Given this list of marker genes CDCA8, RAD54L, TTK, E2F8, POLE, MT2A, REEP5, PMF1, BIRC5, ANXA2, LMNB1, TGM4 (transglutaminase 4), USP4, WDHD1, SHCBP1, MTCH1, ARHGAP11A, RRM1, ANP32E (NCBI Gene Id 81611), PPP2R1B, HELLS, BRCA1, ATAD5, RAD51AP1, SYCE2, BRIP1, CRIP1, CKAP2, TXNRD1, RAD51, MCM5, BUB1B, NEIL3, CDKN3, PYCARD (PYD and CARD domain containing), DNA2, DEPDC1, CTSD, PRIM1, FBXO5, AURKB, KIF23 (kinesin family member 23), SMC2, MCM4, ECT2, KNL1, NHLH1, CKS1B, KIF15, RBM44, CDK1, ORC6, KIF11, CHEK1, IFITM1, DLGAP5, TOP2A, HDLBP, CORO2A, BRCA2, LRR1, INCENP, ARHGAP19, TACC3, SGO2, MT1A, CCNA2, LRRC58, HNRNPA3, BUB1 (BUB1 mitotic checkpoint serine/threonine kinase), ANAPC5, CDC6, NCALD, TADA2A, CSPP1, GZMA, TK1, VCP, CENPS, GNAI2, APOBEC2, SKA1, NCAPH, HIP1, ITGAX, CPOX, SPATA31F3, ANXA4, WDR76, ROM1, MCM7, LIG1, MYO5A, PTGR1, CLSPN, CENPP, ITGAM, TSPAN32, KIF14, ESCO2, MRPS11, TUBE1, NDC80, NCAPD2, PMM1, PCDHB6, STMN1, NCAPG, ZBTB32, KIF4A, TIPIN, NUF2, CBX5, MCM3, FIGNL1 (NCBI Gene Id 63979), RRM2, ASPM, TPX2, PRR11, CENPE, IFNA6, TCF19, RACGAP1, MYBL1, PPP6C, ARF6, EIF5A2, FKBP5, CDC25C, DUT, CPT1A, PLEKHO1, PRC1, AURKA, CCNE1, CDC45 (NCBI Gene Id 8319), CDCA3, VIM (vimentin), H2BP2, PRDX4, SPC24, SPC25, EME1, CENPF, CHAF1B, FHL2, BSCL2, UHRF1, PALM, MKI67, MAD2L1, HMGB3, CCNB2, GGT1 (NCBI Gene Id 91347), SPAG5, CEP55, CENPN, TOPBP1, PBK, KDM4A, RBM45, H4C6, HMMR, NDE1, SGO1, HMGB2, RNASEH2B, GINS1 (GINS complex subunit 1), CALU, PLK1, MIS18BP1, RINL, E2F6, HNRNPUL1, PRKAG1, SLC44A2 (NCBI Gene Id 57368), RFC3, MYADM, NUPR1, TFDP1, PLAC8, H1-5, ASF1B, FKBP2, CENPH, EIF3C (eukaryotic translation initiation factor 3 subunit C), LSP1, here is a description of the gene set: Human Gene Set: GSE13547_CTRL_VS_ANTI_IGM_STIM_BCELL_12H_UP from publication Arenzana TL, Smith-Raska MR, Reizis B (PMID 19329779) Genes up-regulated in B lymphocytes: control versus stimulated by anti-IgM for 12h. The development, homeostasis and function of B lymphocytes involve multiple rounds of B cell receptor (BCR)-controlled proliferation and prolonged maintenance. We analyzed the role of transcription factor Zfx, a recently identified regulator of stem cell maintenance, in B cell development and homeostasis. Conditional Zfx deletion in the bone marrow blocked B cell development at the pre-BCR selection checkpoint. Zfx deficiency in peripheral B cells caused impaired generation of the B-1 cell lineage, accelerated B cell turnover, depletion of mature recirculating cells, and delayed T-dependent antibody responses. Zfx-deficient B cells showed normal proximal BCR signaling, but impaired BCR-induced proliferation and survival. This was accompanied by aberrantly enhanced and prolonged integrated stress response, and delayed induction of Cyclin D2 and Bcl-xL proteins. Thus, Zfx restrains the stress response and couples antigen receptor signaling to B cell expansion and maintenance during development and peripheral homeostasis. species: Homo sapiens